Given this list of marker genes Prdx6, Fes, Gsr, Ftl1, Ipcef1, Gpx3, Glrx2, Prdx2, Oxsr1, Egln2, Prdx4 (NCBI Gene Id 53381), Glrx, Hmox2, Ptpa, Gpx4, Cdkn2d, Lamtor5, G6pdx, Ndufa6, Sod1, Prdx1, Lsp1, Pfkp, Txn1 (thioredoxin 1), Atox1, Ndufs2, Stk25, Txnrd2, Hhex, Gclc, Scaf4, Sbno2, Pdlim1, Txnrd1, Junb, Prnp, Nqo1, Cat, Selenos, Srxn1, Ercc2 (NCBI Gene Id 13871), Abcc1, Mbp, Msra, Gclm, Mpo, Mgst1, Sod2, here is a description of the gene set: from publication Howe DG, Blake JA, Bradford YM, Bult CJ, Calvi BR, Engel SR, Kadin JA, Kaufman TC, Kishore R, Laulederkind SJF, Lewis SE, Moxon SAT, Richardson JE, Smith C (PMID 30224793) Mouse genes annotated to HALLMARK_REACTIVE_OXYGEN_SPECIES_PATHWAY based on orthology mappings provided by the Alliance Genome Consortium Mouse Gene Set: HALLMARK_REACTIVE_OXYGEN_SPECIES_PATHWAY studied in species Mus musculus